The following is a description of a gene set: The gene expression program underlying the specification of human cell types is of fundamental interest. The study authors generated human cell atlases of gene expression and chromatin accessibility in fetal tissues. For gene expression, the study authors applied three-level combinatorial indexing to >110 samples representing 15 organs, ultimately profiling ~4 million single cells. The study authors leveraged the literature and other atlases to identify and annotate hundreds of cell types and subtypes, both within and across tissues. Our analyses focused on organ-specific specializations of broadly distributed cell types (such as blood, endothelial, and epithelial), sites of fetal erythropoiesis (which notably included the adrenal gland), and integration with mouse developmental atlases (such as conserved specification of blood cells). These data represent a rich resource for the exploration of in vivo human gene expression in diverse tissues and cell types. species: Homo sapiens Human Gene Set: DESCARTES_FETAL_EYE_LENS_FIBRE_CELLS Marker genes curated from the annotated cluster as represented in the Descartes Human Gene Expression During Development database. from publication Cao J, O'Day DR, Pliner HA, Kingsley PD, Deng M, Daza RM, Zager MA, Aldinger KA, Blecher-Gonen R, Zhang F, Spielmann M, Palis J, Doherty D, Steemers FJ, Glass IA, Trapnell C, Shendure J (PMID 33184181), and this is the list of marker genes: CAST, HMSD, BFSP2, CRYGC, GACAT3, GJA3, MED12L, CRYGEP, TIMELESS, LCTL, BHMT, CRYGS, LINC01440 (long intergenic non-protein coding RNA 1440, NCBI Gene Id 102723578), VIT, COL4A6, LINC01170, GJA8, ARSI, LINC02624, ADRA1B, LIM2, ME1, MYO18A, PITX3, RMST, RSPO4, SOX1, EFCAB8, CRYBA1, CAMK2A, CAPRIN2, TRPM8, PALM2AKAP2, TDH, LINC01339, CRYGD, CARD14, UPP1, CRYBA4, RNU5E-8P, LINC01885, DNMBP, LSAMP, LINC02024, LINC02160, MIP, P3H2-AS1, PITHD1, SLC24A2, LINC03051, HSPA6, DRG1P2 (DRG1 pseudogene 2), CRYBB2 (NCBI Gene Id 879), PLEKHG7, PIP5KL1, WNT7A, CERK, CRYBB3, LINC02763, TMEM114, F12, BIRC7, ENSG00000243276, MIR193BHG, CRYBB1, FBXL21P, LINC02367, ZNF778-DT (ZNF778 divergent transcript), CHRNA2, LINC02698, GSS, SORD, LNPK, LINC02413, NREP-AS1, NEURL2, RAB39A, SLC27A6, LGSN, CRYGB, KMO, CRYAA (NCBI Gene Id 1409), CRYBA2, BFSP1, CRYGA, SQOR, CRMA, MBOAT1, CCDC169, LINC00519, HTR1E, NOCT